Given this list of marker genes Nemp2, Sod2, Phf20l1, Psg16, Fzd4, Ankrd10, Cnep1r1, Glyat, Dlg1, Dnajc14, Mafb, Pitpna, Lin7c, Gpr152, Misp3, Slc25a5, Scamp5, Ttl, Aebp2, Vegfa, here is a description of the gene set: species: Mus musculus from publication Chen Y, Wang X (PMID 31504780) Genes predicted to be targets of miRBase v22 microRNA mmu_miR_543_5p in miRDB v6.0 with MirTarget v4 prediction scores > 80 (high confidence targets). Mouse Gene Set: MIR_543_5P